The following is a description of a gene set: studied in species Mus musculus This event has been computationally inferred from an event that has been demonstrated in another species.<p>The inference is based on the homology mapping from PANTHER. Briefly, reactions for which all involved PhysicalEntities (in input, output and catalyst) have a mapped orthologue/paralogue (for complexes at least 75% of components must have a mapping) are inferred to the other species. part of: DAP12 interactions Reactome Pathway: DAP12 signaling electronically inferred by orthology from the curated human pathway, and this is the list of marker genes: Klrd1, Pik3cb, Klrk1, Trem2, Grap2, Pik3r2, Plcg2, Tyrobp, Grb2, Hras, Klrc1, Fyn (NCBI Gene Id 14360), Klrc3, B2m (beta-2 microglobulin), Lcp2, Lat, Shc1, Klrc2, Syk, Lck